The following is a description of a gene set: Mouse Gene Set: REACTOME_CELL_CYCLE_CHECKPOINTS Cell Cycle Checkpoints studied in species Mus musculus, and this is the list of marker genes: Cenpo, Kif2b, Spdl1, Mcm8, Sec13 (SEC13 homolog, nuclear pore and COPII coat complex component), Cdkn1c, H2bc23, Pmf1, Pias4, Psma2, Ywhah (NCBI Gene Id 22629), Psma3, Ndc80 (NDC80 kinetochore complex component), Psma6, H4c11, Rfc4, Ube2e1, Psma1, Ppp2cb, Psmd7, Anapc7, Bub1, Uba52rt, Cenpc1, Dynll2, Psmb1, H2bc7, Kif2a, Ppp2r5e (NCBI Gene Id 66702), Psma5, Cdc25c, Cenpp, Ppp2r5b, Rmi1, Anapc15 (anaphase promoting complex C subunit 15), Kat5, Dynll1, Cenpn, Spc24, Cdc16, Ska1, Rps27rt, Psmc3, Rad50, Psma7, Cdc6, Mad1l1, Ywhag, Cenpk, Bub3 (BUB3 mitotic checkpoint protein), Cenpf, H3f4, Orc5, Nup43, Anapc16, H2bc15, Nde1, Rbbp8, Ckap5, Trp53bp1, H4c14, Ube2n, Mdm2, Atm, Orc4, Babam2, Mdc1 (NCBI Gene Id 240087), Anapc4, Cenph, Wee1, Clasp2, Abraxas1, Psma4, Psmb5, Psmd2, Psmc4, Mcm10, Dync1li2, Phf20, Mdm4, Brip1, Zfp385a, H2bc13, Pafah1b1, Incenp, H2bc14, Dync1i2, Anapc2, Atrip, Uba52, Rmi2, H4c12, Psmc1, Sfn, Ube2d1, Anapc10, Cenpa (NCBI Gene Id 12615), Nup37, Cdc45, Ppp2r5c, Anapc11, Nbn, H2bc12, Ubc, H2bc9, Cop1, Wrn, Rfc2, Orc2, Chek2, Ahctf1, Pkmyt1, Nuf2, Mcm7, Rfc3, Kntc1, Adrm1, Rad9a, Cdc23, Psmd8, Mis12, Rps27, H2bc3, Ccne2, Bub1b, H2bc24 (NCBI Gene Id 671645), Rad1, Rpa3, Ccnb1, Ska2, Trp53 (NCBI Gene Id 22059), Cdkn1b, Brcc3, Cdc7, H2bc26, H4c1, Ube2c, Psmd12, Rfc5, Nudc, Ppp2ca, Psmc6, Cenpt, Psmd1, Ube2s, H4c9, Nup107, Spc25, H2bc1, Plk1, Cenpi, Psmd3, Top3a, Ercc6l, H4c3, Dsn1, H4c2, Anapc5, Nup133, Psmb3, Ccna1, Hus1, Cdk1, Orc3, Seh1l, Zwilch, Uimc1, B9d2, Dna2, Ccne1, Ube2v2, Psmd6, H4c6, Rad9b, Dbf4, Ppp2r1a, Rangap1, Gtse1, Aurkb, Psmb2, Cenps, Rnf8, H2bc8, Rhno1, Mcm2, Mapre1, H2bc6, H4c8, Exo1, Orc1, Ubb, Mcm5, Clspn (claspin), Clasp1, Nup98, Cdk2, Psmc5, Psmb4, Mcm6, Dync1h1, H2bc21, Ranbp2, Rcc2, Mcm4, Sgo1, Rpa2, Ppp2r5d, Ppp1cc, Topbp1, Zw10 (zw10 kinetochore protein), Cdkn1a, Ccna2, Xpo1, H4c17, Taok1, H4c16 (H4 histone 16), Cenpe, Ndel1, Kif2c, Zwint, Nsl1, Ywhab, H4c4, Psmd11, Mcm3 (minichromosome maintenance complex component 3), Dync1i1, Herc2, Psmb7, Cenpm, Ywhaq, Clip1, Dync1li1, Ppp2r5a, H2bc22, H4c18, Psmd14, Psmc2, Itgb3bp, Bard1, Ywhaz, Psmd13, Ccnb2, Cenpq, H2bc11, Rps27a, Mad2l1, Rpa1, Rad17, Cdc25a, Cdc27, Ywhae, Cdc20, Nup160, Chek1, Mre11a, Anapc1 (NCBI Gene Id 99393), Babam1, Cdca8, Cenpl (NCBI Gene Id 98714), H2bc4, Psmb6 (NCBI Gene Id 19175), Nsd2, Cenpu, Cdc26, Brca1, Rnf168, Orc6, Nup85, Blm, H2ax, Kif18a, Sgo2a, Ppp2r1b